The following is a description of a gene set: Severe mental retardation is defined as an intelligence quotient (IQ) in the range of 20-34. Human Gene Set: HP_INTELLECTUAL_DISABILITY_SEVERE species: Homo sapiens Intellectual disability, severe, and this is the list of marker genes: TBR1, PPP1R15B, FGFRL1, PIGT, ZBTB18, SNAP29, AMMECR1, UBE3A (NCBI Gene Id 7337), EHMT1, CRBN, SOBP, HERC1, SLC6A17, SRPK3, NIN, ANKLE2, ITPR1, HNMT, SHROOM4, TFE3, TAF13, GMPPB, CYB5R3, MAB21L1, DHX9, FGFR3, MBD5, CC2D1A, NSD2, PPP2R1A, GABBR2, TBC1D23, SLC35C1, UBA5, UBE3B, PLEKHG2, PIGL, GABRA5, SMOC1, KCNE5 (NCBI Gene Id 23630), TRAPPC9, PPIL1, ARG1, KAT5, ARID2, HDAC8, TRIM8, SLC26A4, CUL4B, PCNA, WBP4, CEP135, DMPK, TAF6, ZNHIT3, WDR81, STIL, GNPAT, NACC1, TUBA1A, PEX7, DAG1, MFSD2A, NKX2-5, PIGU, PAK3, CEP85L, KIF5C, MEF2C, ASXL3 (NCBI Gene Id 80816), PAH, AP4E1, MCPH1, COLGALT1, BCORL1, BCKDK, TMEM163, DYM, WDR62, PAK1, KCNH1, PNKP, CAMK2A, WDR11, PDHX, DNMT3A, GAMT, PSMC1, ARID1A, TMEM107, KANSL1, PIGW (phosphatidylinositol glycan anchor biosynthesis class W), DYNC1I2, PHYH, WASF1, GNAO1, SMARCA2, ASXL1, TSHR, FKRP, PDX1, ATP9A, CTNNA2, PURA, FOXP1, VPS4A, NEU1, TOR1A, UBE3C, KCNJ11, ATP6V0C, SCN2A, SRD5A3, PPP2R5D, SLC35A2, THOC2, WARS1, PIK3CA (NCBI Gene Id 5290), PGAP2, TMX2, P4HTM, TIMM50, LARP7, PGAP1, PIGY, TRAPPC6B, RAD21, FUCA1 (alpha-L-fucosidase 1), SMARCB1, L1CAM, RAB5IF, LMAN2L, SUCLG1, NDE1, EIF4A2 (NCBI Gene Id 63124), CDK5RAP2, THOC6, SOX11, GOT2, YY1, SPTAN1, ARFGEF2, RAC3, DPYSL5, KDM5C, CDC40, CCNK, BRD4, AP4B1, STAG1, CHD8, NANS (N-acetylneuraminate synthase), METTL5, INPP5E, MTOR, GLI3, EIF2S3, ADGRG1, ATIC, BRF1, CTBP1, SIN3A, SARS1, SCN1A, FRRS1L, OPHN1, GALNT2, MECP2, NSD1, SNRPN, CEP152, SMARCA4, CCND2, SMARCD1, EPB41L1, SEMA6B, PHC1, POMT2, KCNC2, PLP1, AFG2A, MACF1, ACTL6B, CNTNAP2, AP4S1, PUS3, ZNF407, ADCY5 (NCBI Gene Id 255218), STAT3, SLC16A2, C2CD3, ROGDI, CENPE, NKX2-1, COPB2, SLC35A3, FTCD, MAN1B1, DPAGT1, HNRNPC, RTTN, FAT4, SYNGAP1, PLAA, SATB2, UBE4A, NAGA, DCHS1, GRIA1, ASPM, CTSD, HMGCL, BCAS3, PYCR2, ARX, LMX1B, FZR1, GLI2, CUL3, UBTF, CEP63, OTUD6B, SASS6, GCK, PRSS12, SLC13A5, MPV17, ALG14, TELO2, NUP37, SLC12A2, GATAD2B, PRMT7, INS, MBTPS2, SHMT2, PEX1, FGF13, ACAT1, ACSL4, HSD17B10, MYT1L, SMC1A (structural maintenance of chromosomes 1A), EXT2, NALCN, FOXG1, ACER3, CA2, SATB1, NIPBL, KCNJ6, AKT3, MT-ATP6, UNC80, COG5, GRIN1, UBE2A (NCBI Gene Id 7319), SMARCC2, RAB3GAP1, AHSG, TUSC3 (NCBI Gene Id 7991), HNRNPH1, TRAPPC10 (trafficking protein particle complex subunit 10), HNRNPK, RAB18, NRXN1, CIT, COPB1, AP1S2, CHRNA7, FOXE1, SNX14, LETM1, ERLIN2, HPD, KIF7, UQCRQ, STXBP1, FKTN, SLC1A2, RPL10, ALG2, DLAT, ARID1B, ABCC8 (NCBI Gene Id 6833), SPTBN4, ZEB2, PIGF, RNU4-2, APC2, NCAPD3, FRMD4A, MPDU1, CDK6, ZFX, PGAP3, PSMB1 (NCBI Gene Id 5689), ARHGEF9, KAT6A, TSHB, PAX8, PAFAH1B1, CPLX1, ATRX, GDI1, LARGE1, SOX4, TTI2, INTS11, TBC1D20, KNL1, ACO2, POMGNT1, PHF6, DPF2, AMT, SEMA5A, MCM7, CLCN4, ALG13, SLC25A15, PIGO, MGAT2, HTT, KLF13, CACNA1D, SMC3, EEF1A2, BCAP31, OFD1, GRIN2A, PIGV, NELFA, TRMT10A, AHDC1, CYB5A, KMT2B, KIF14, TMEM237 (NCBI Gene Id 65062), EML1, WIPI2, LINGO1, HNRNPU, CAMK2G, PEX5, ACOX1, POMT1, AP4M1, KAT6B, SMARCE1, SON, CTNND2 (catenin delta 2), PCDH19, POGZ, GNB5 (NCBI Gene Id 82962), PTEN, L2HGDH, NTRK2, IQSEC2, PIGG, TCF4, DYRK1A, TPR, PRUNE1, FCSK, RFT1, SLC9A6, GRIA3, SUOX, SCN8A, RAB3GAP2, NFIX, PQBP1, OCA2, TRAPPC14, RNF2, IQSEC1